The following is a description of a gene set: species: Homo sapiens The directed movement of a cyclic nucleotide, any nucleotide in which phosphate group is in diester linkage to two positions on the sugar residue, into, out of or within a cell. Human Gene Set: GOBP_CYCLIC_NUCLEOTIDE_TRANSPORT, and this is the list of marker genes: LRRC8B, LRRC8A, ABCC4 (NCBI Gene Id 10257), SHOC2, ABCC5, SLC19A1, LRRC8D, LRRC8C, ABCC1, SLC46A2, LRRC8E